The following is a description of a gene set: species: Homo sapiens To better define the molecular basis of multiple myeloma (MM), we performed unsupervised hierarchic clustering of mRNA expression profiles in CD138-enriched plasma cells from 414 newly diagnosed patients who went on to receive high-dose therapy and tandem stem cell transplants. Seven disease subtypes were validated that were strongly influenced by known genetic lesions, such as c-MAF- and MAFB-, CCND1- and CCND3-, and MMSET-activating translocations and hyperdiploidy. Indicative of the deregulation of common pathways by gene orthologs, common gene signatures were observed in cases with c-MAF and MAFB activation and CCND1 and CCND3 activation, the latter consisting of 2 subgroups, one characterized by expression of the early B-cell markers CD20 and PAX5. A low incidence of focal bone disease distinguished one and increased expression of proliferation-associated genes of another novel subgroup. Comprising varying fractions of each of the other 6 subgroups, the proliferation subgroup dominated at relapse, suggesting that this signature is linked to disease progression. Proliferation and MMSET-spike groups were characterized by significant overexpression of genes mapping to chromosome 1q, and both exhibited a poor prognosis relative to the other groups. A subset of cases with a predominating myeloid gene expression signature, excluded from the profiling analyses, had more favorable baseline characteristics and superior prognosis to those lacking this signature. Top 50 down-regulated genes in cluster CD-2 of multiple myeloma samples with the charachteristic expression spike of CCND3. Human Gene Set: ZHAN_MULTIPLE_MYELOMA_CD2_DN from publication Zhan F, Huang Y, Colla S, Stewart JP, Hanamura I, Gupta S, Epstein J, Yaccoby S, Sawyer J, Burington B, Anaissie E, Hollmig K, Pineda-Roman M, Tricot G, van Rhee F, Walker R, Zangari M, Crowley J, Barlogie B, Shaughnessy JD Jr (PMID 16728703), and this is the list of marker genes: HK2, TDO2 (tryptophan 2,3-dioxygenase), CHAC2, LATS2, HSPA4L, FABP5, GPR37, MRPS30, ANXA2, HMGA1, POLR3G, OSBPL3, ZNF593 (zinc finger protein 593), TXN, NFIA, NEDD4, BZW2, AVEN, GART, THEM4, PPA1, POLR2H, BOP1, MSRB3, SORD, PFKFB2, PLAAT3, JPT1, USP45, PRICKLE2, PAQR6, RRAGD, MCC, H1-2, GJB2, UCK2, FAM171A1, C1orf53, JAK3, CR2, MREG, MB21D2, LDHA, POGLUT1, GPRC5D, FASN, MFNG